Given this list of marker genes SRP54, DPP9, IKZF1, PSMB9, TNFRSF4, CXCR4, HAVCR2, DHFR, DKC1, PCCB, BRCA2 (NCBI Gene Id 82716), MRPS7, ELANE, DNAJC21, GATA1, TERT, COG6, RPA1, NAXD (NCBI Gene Id 95526), SAMD9 (NCBI Gene Id 54809), GBA1, SF3B1, TGFB1, DDX41, ADA2, STX11, LRBA, TNFSF11, PARN, LMBRD1, XIAP, STN1, NOP10, FIP1L1, ERCC6L2, CLCN7, WRAP53, RFXAP, GATA2, ANAPC1, TCF3, MMAA, TET2, FANCL, RAD51, ACBD6 (acyl-CoA binding domain containing 6), PALB2, STXBP2, MYSM1, TCIRG1, ZBTB16, RAP1B, FANCE, RECQL4, GFI1B (NCBI Gene Id 8328), MPL, TNFRSF9, PSTPIP1, ZNF699, XRCC4, SH2B3, BCOR, ALPK1, ERCC4, FANCA, LBR, LIG4, RPL26, SH2D1A, THPO, GNAS, NBEAL2, FLI1, PRF1, COQ2, RFXANK, DUT, SRP19, BRIP1, RPS14, TLR8, NPM1, SLC30A7, HOXA11, MMAB, MAD2L2, IFIH1, NUMA1, DCLRE1B, FARSB, DNASE2, CUBN, KRAS, CIITA, MPIG6B, PGM3, NBN, NHP2, TERC, RUNX1, SCARB2, RTEL1, CLPB, FANCI, HLA-DRB1, SLC7A7, RARA, TCN2, ATR, EFL1, FANCD2, SRSF2, SBDS, BACH2, CD27, TALDO1 (NCBI Gene Id 6888), CASP10, SLC46A1, UNC13D, SARS2, GFI1, CALR, ACD, ASXL1, SP110, SLX4, IFNG, NLRC4, SMARCAL1, USB1, CBL, NABP1, NRAS, STAT3, LYST, GALE, VPS33A, TP53, PTPRC, ADH5 (NCBI Gene Id 2223), SRC (SRC proto-oncogene, non-receptor tyrosine kinase), RAC2, MAN2B1, TBXAS1, JAK2, ACP5, FAS, MTHFD1, RAB27A, PDCD1, PIGA, UBE2T, SLC19A1, FANCC, ZCCHC8 (NCBI Gene Id 55596), PCCA, PRKAR1A, KIT, ABCB7, SRP72, STAT5B, PML, AMN (NCBI Gene Id 81693), WDR19, CTC1, TYMS, SAMD9L, ITCH, FASLG, MDM4, RFX5 (regulatory factor X5), RNASEH2A, IRF2BP2, TINF2, MTRR, CA2, FANCF, FANCB, IVD, TBL1XR1, SHOC2, ITK, OSTM1, MMADHC, here is a description of the gene set: Human Gene Set: HP_ABNORMALITY_OF_MULTIPLE_CELL_LINEAGES_IN_THE_BONE_MARROW Abnormality of multiple cell lineages in the bone marrow species: Homo sapiens